Given this list of marker genes Slc6a8, Ly6c2, Plxnb2 (NCBI Gene Id 73840), Thy1, Selenof, Ccnd1, Marcksl1, Timp2, Tmem45a, Tagln2, Dlk1, Actn1, S1pr3, Vcam1, Nono, Apbb2, Pbx3, Ctla2a, Rhoj, Bag6, Nqo1, Synpo, Pros1, Pnp, Prrx2, Plp2, Timp1, Tinagl1, Fbn1, Cd44 (CD44 antigen), Plac8, Ifitm3, Cttn, Slc29a1 (solute carrier family 29 (nucleoside transporters), member 1), Cpe, Vamp5, Ccn5, H2az2, Hmga2, Ly6a, Dnm1, Ptgs1, Il6st, Rbp1, Serpine2, Fbln2, Ssr3, Xpo1, S100a6, Tpm4, Tgfbi, Ctsl, here is a description of the gene set: During cellular differentiation and development, it is recognized that many complex molecular mechanisms as well as precise patterns of differentially expressed genes occur in directing precursor cells toward a given lineage. Using microarray-based technology, we examined gene expression across the course of 3T3-L1 adipocyte differentiation. Total cellular RNA was isolated at times 0, 2, 8, 16, 24, 48, and 96 h following treatment with either standard hormonal inducers of differentiation; insulin, dexamethasone, isobutylmethylxanthine (IDX), or IDX plus trichostatin A (TsA), a histone deacetylase inhibitor and potent adipogenic inhibitor. cRNA was synthesized from cellular RNA and hybridized to high density Affymetrix MG_U74Av2 microarray gene chips containing 12,488 cDNA/Expressed Sequence Tags (ESTs) probe sets. From the IDX-only treated cells, all probe sets that were either unchanged or differentially expressed less than 2-fold throughout differentiation with respect to time 0 preadipocytes were excluded from further analyses. This selection resulted in a net of 1686 transcripts, 859 were increased in expression, and 827 were decreased in expression at least 2-fold across differentiation. To focus in on genes that were more specific to differentiation, the same analysis was performed on IDX plus TsA-treated non-differentiating cells and all probe sets from the IDX-only group that exhibited similar expression profiles in the non-differentiating TsA-treated group were excluded leaving a total of 1016 transcripts that were regulated only under differentiating conditions. Six hundred and thirty-six of these transcripts were elevated at least 2-fold and 380 exhibited a decrease in expression relative to time 0 preadipocytes. This group of genes was further analyzed using hierarchical clustering and self-organizing maps and resulted in the identification of numerous genes not previously known to be regulated during adipocyte differentiation. Many of these genes may well represent novel adipogenic mediators and markers of adipogenesis. Down-regulated at 48-96 h during differentiation of 3T3-L1 cells (fibroblast) into adipocytes. Mouse Gene Set: BURTON_ADIPOGENESIS_7 from publication Burton GR, Nagarajan R, Peterson CA, McGehee RE Jr (PMID 15033539) species: Mus musculus